Given this list of marker genes Nfatc1, Nfatc2, Pdgfb, Nfatc3, Ereg, Prdm6, Pdcd4, Hey1, Hey2, Mecp2, Med28, Ankrd17, Fgf9, Dnmt1, Shh, Foxo4, Rbpms2, Rcan1, here is a description of the gene set: Mouse Gene Set: GOBP_NEGATIVE_REGULATION_OF_SMOOTH_MUSCLE_CELL_DIFFERENTIATION species: Mus musculus Any process that stops, prevents, or reduces the frequency, rate or extent of smooth muscle cell differentiation.